The following is a description of a gene set: Mouse Gene Set: CUI_T_CELL_CD4_RESISTIN_RESPONSE_DN studied in species Mus musculus Genes negatively differentially expressed in cell type: CD4+ T cell upon treatment with cytokine: ADSF in mouse lymph nodes in vivo. Cytokines mediate cell-cell communication in the immune system and represent important therapeutic targets. A myriad of studies have highlighted their central role in immune function, yet we lack a global view of the cellular responses of each immune cell type to each cytokine. To address this gap, the authors created the Immune Dictionary, a compendium of single-cell transcriptomic profiles of more than 17 immune cell types in response to each of 86 cytokines (>1,400 cytokine-cell type combinations) in mouse lymph nodes in vivo. A cytokine-centric view of the dictionary revealed that most cytokines induce highly cell-type-specific responses. For example, the inflammatory cytokine interleukin-1β induces distinct gene programmes in almost every cell type. A cell-type-centric view of the dictionary identified more than 66 cytokine-driven cellular polarization states across immune cell types, including previously uncharacterized states such as an interleukin-18-induced polyfunctional natural killer cell state. from publication Cui A, Huang T, Li S, Ma A, Pérez JL, Sander C, Keskin DB, Wu CJ, Fraenkel E, Hacohen N (PMID 38057668), and this is the list of marker genes: Junb, Tsc22d3, Fos, Jun, Uba52, Hspa1b, Hspa1a (NCBI Gene Id 193740), Klf6